Given this list of marker genes Kdm7a, H2az2, Txnip, Map4k4, Btg2, Stk17b, St3gal6, Selenop, Thy1, Ncor1, Cenpa, Sdc1, Rhob, Cited2, Macf1, Ly6c2, Tcf7, Paip2 (polyadenylate-binding protein-interacting protein 2), Crtc3, Themis, Zfp36l2, Il18r1, Cd7, Entrep3, Kif21b, Ctsd, Junb, Fos, Crip1 (NCBI Gene Id 12925), Hmgb2, S1pr1, Tsc22d3, Ypel3, Rgs10, Emp3, Add1, S100a10, Pnrc1, Uba52, Acp5, Lef1, Add3, Ets1, Txk, Rgs2, Bnip3l, Itga4, Klhl24, Grk2, Mxd4, Ppp1r15a, Crlf3, Hipk1 (NCBI Gene Id 68849), Adgre5, Il7r, Smc4, Chd9, Klf2, Pdcd4, Cox7a2l, Hcst, Fyb1, Ostf1, Cxcr4, Traf1, Rasgrp2, Nfatc3, Klrk1, Smad7, Cmah, Ccl5, Neat1, Adcy7, Sh3kbp1, Arl5c, Lsp1, Akap13, Arhgap45, Ndufa6, Cir1, here is a description of the gene set: Mouse Gene Set: CUI_T_CELL_GD_IL15_RESPONSE_DN from publication Cui A, Huang T, Li S, Ma A, Pérez JL, Sander C, Keskin DB, Wu CJ, Fraenkel E, Hacohen N (PMID 38057668) Genes negatively differentially expressed in cell type: γδ T cell upon treatment with cytokine: IL-15 in mouse lymph nodes in vivo. Cytokines mediate cell-cell communication in the immune system and represent important therapeutic targets. A myriad of studies have highlighted their central role in immune function, yet we lack a global view of the cellular responses of each immune cell type to each cytokine. To address this gap, the authors created the Immune Dictionary, a compendium of single-cell transcriptomic profiles of more than 17 immune cell types in response to each of 86 cytokines (>1,400 cytokine-cell type combinations) in mouse lymph nodes in vivo. A cytokine-centric view of the dictionary revealed that most cytokines induce highly cell-type-specific responses. For example, the inflammatory cytokine interleukin-1β induces distinct gene programmes in almost every cell type. A cell-type-centric view of the dictionary identified more than 66 cytokine-driven cellular polarization states across immune cell types, including previously uncharacterized states such as an interleukin-18-induced polyfunctional natural killer cell state. studied in species Mus musculus